The following is a description of a gene set: Human Gene Set: PID_NOTCH_PATHWAY Notch signaling pathway studied in species Homo sapiens from publication Schaefer CF, Anthony K, Krupa S, Buchoff J, Day M, Hannay T, Buetow KH (PMID 18832364), and this is the list of marker genes: RBBP8, SKP2, APH1B, DLK1, DTX1 (NCBI Gene Id 1840), CNTN1, EP300, ADAM10, CUL1, ENO1, NEURL1, CNTN6, FBXW7, CDKN1A, CTBP1, JAG1 (jagged canonical Notch ligand 1), SSPOP, MYC (MYC proto-oncogene, bHLH transcription factor), LNX1, ADAM12, PSEN1, RAB11A, NOTCH3, IL4, YY1, MIB1, CCND1, DNER, MFAP2, FURIN, NCOR2, DLL3, DNM1, SKP1, NOTCH1, DLL4, RBPJ, ITCH, PTCRA, APH1A, CBL, NUMB, SPEN (spen family transcriptional repressor), MAML2, PSENEN, MARK2, MAML1, NOTCH4, NOTCH2, EPS15, GATA3, MFAP5, HDAC1, KDM1A, JAG2, NCSTN, DLL1, MYCBP, NCOR1